Given this list of marker genes PATJ, GJA5, RAB13, SMAD3, CDC42, LIMS2, NPHS1, CDH5, SLC39A9, FSCN1, NLGN4X, FERMT2, EFNB2, CLDN24, DSP, EPHA2, ABI2, DLG5, OCEL1, RAC1, CLDN4, SNAI1, ANK2, CLDN10, F11R, CSK (NCBI Gene Id 1445), CLDN9, DSG1, FZD5, CLDN18, DSG2, CLDN12, KIRREL1, HEG1, MARVELD2, SVEP1, TRPV4, GRHL1, CCM2, PRKCA, PLEKHA7, CLDN17, CTNNA1, AMOT, NLGN2, TGFB1, CDH6, JAM3, RDX, PKP4, TBCD, ROCK2, HOPX, LIMS1, TGFBR1, CLDN14, TJP2, EPB41L3 (erythrocyte membrane protein band 4.1 like 3), KIFC3, HIPK1, GJA1, GPBAR1, ADAM10, AGT, MYO1C, CLDN5, TJP1, UGT8, BMP6, STRN, CDH17, CLDN3, NPHP1, CXADR, CLDN25 (NCBI Gene Id 649326), PKHD1 (PKHD1 ciliary IPT domain containing fibrocystin/polyductin), PERP, PARD6A, TGFB3, FLCN, CNTNAP2, ACTG1, KPRP, SPECC1L, CDHR3, F2RL1, CLDN1, CSF1R, AFDN, CDH4, CDH8, CDH22, CD9, CDH13 (NCBI Gene Id 1012), POF1B, WHRN, WDR1, CDH12, JUP, GJB6, SNAI2, ECT2, NR1H4, CLDN34, GJB2, PKN2, MTSS1, NF2, IRX3, CDH9, MIR105-1, EPHA4, CLDN23, WNT11, GRHL2, MPDZ, APC, CDH10, MPP7, MIR142, SMAD7, PLEC, FER, PKP1, MICALL2, CDH15, GNPAT, PDCD6IP, LSR, ABCC8, CD177, RHOA, PRKACA, TJP3, ACE2, CLDN20, XIRP2, RHOC, CLDN7, CAV1, CLDN6, PAK2, ACTB, CDH24 (cadherin 24), PRTN3, CLDN15, ACVRL1, GJA4, PIP5K1C, PARD3, AJM1, ILDR1 (NCBI Gene Id 449482), RPS6, CD2AP, NUMBL (NCBI Gene Id 9253), OCLN, DSG3, MARVELD3 (NCBI Gene Id 91862), DLG1, CLDN19, SRF, PTPRO, ZNF703, HDAC7 (histone deacetylase 7), TNF, GDF2 (NCBI Gene Id 51423), PRKCH, NPHP4, GJB1, NUMB, FKRP, PECAM1, CDH18, IL1B, INAVA, VEGFA, IL17A, APLNR (NCBI Gene Id 187), GJC1, CLDN11, ARL2, CLDN2, PARD6B, FBF1, CLDN16, TGFB2, ESAM, ACE, MYLK3, CAMSAP3, PKP2, DSC1, CNTNAP1 (NCBI Gene Id 8506), CDH20, CDH1, EXT1, BHLHA15, CLDN8, NECTIN1, ROCK1, CDH19, CDH2, TLN1 (talin 1), EPHB2, PRKCI, VCL (vinculin), CTNNB1, LIM2, TBX5, PKP3, MYADM, PTPN23, CDH3, GJD3, CLDN22, FRMPD2, CDH7, RAMP2 (receptor activity modifying protein 2), ADD1, F2R, IKBKB, TLN2, CDH11, TMIGD1, CDH26, here is a description of the gene set: studied in species Homo sapiens A process that is carried out at the cellular level which results in the assembly, arrangement of constituent parts, or disassembly of a cell-cell junction. A cell-cell junction is a specialized region of connection between two cells. Human Gene Set: GOBP_CELL_CELL_JUNCTION_ORGANIZATION